Given this list of marker genes IL1B, BMP7, CD44, NR4A3, HAS2, here is a description of the gene set: Human Gene Set: GOBP_MONOCYTE_AGGREGATION species: Homo sapiens The adhesion of one monocyte to one or more other monocytes via adhesion molecules.